The following is a description of a gene set: Mouse Gene Set: GOBP_POSITIVE_REGULATION_OF_ADENYLATE_CYCLASE_ACTIVITY studied in species Mus musculus Any process that activates or increases the frequency, rate or extent of adenylate cyclase activity., and this is the list of marker genes: Nf1, Raf1, Lhcgr, Acr, Cacna1d, Adcy4 (adenylate cyclase 4), Calca, Gnal, Adcy7, Adcy2, Adcyap1, Stim1, Drd1, Adcy1, Calcr, Orai1, Cacna1c, Adcy3